Given this list of marker genes DLG1, CHAT, SNAP25, KCNJ8, TUBA1B, HCN3 (hyperpolarization activated cyclic nucleotide gated potassium channel 3), LIN7B, IL1RAP, LIN7A, HOMER2, KCNA2, PRKCG, PRKAR1B, RASGRF2, GRIP2, HCN2, GRIK3, KCNK16, GABRR1, SLC1A1, GABRR3, KCNV2, SYN1, NRGN, SHANK1, KCNH6, KCND3, GRIN2C, KCNG1, KCNK18, LRRC7, GABRA4, CACNG2, SLC6A4, ADCY4, PRKAR2B, GNG3, DLG2, RASGRF1, SLC6A3, TUBA1C, GRIK2, TUBAL3, SLC5A7, GABRR2, EPB41L5, SLC18A2, HRAS, KCNAB2, GNAL, AP2S1, KCNA7, VAMP2, PANX2, APBA2, EPB41, PRKAG3, KCNN2, ADCY5, SHANK2, GABBR1, SLITRK6, KCNN3, EPB41L1, TUBB6, SLC1A6, GABRB1, ABAT, PRKAG2, HOMER3, TUBB4A, GNAI3, KCNC1 (NCBI Gene Id 3746), NLGN2, DLG3, IL1RAPL2, GNG7, KCNAB1, PPFIBP1, KCNS1, PDPK1, LRFN3, PTPRF, CHRNA7, KCNH2, KCNS2, PPFIA3, NRG1, COMT, KCNK10, GRIN2A, SLC6A12, GNG12, KCNA1, KCNMB4, CHRNB3, GNG4, KCNK6, KCNA4, ACHE, SLITRK5, SLITRK4, KCNJ11, PPM1E, PRKAR1A, CREB1, GNG10, RPS6KA6 (NCBI Gene Id 27330), CHRNE, KCNJ9, LRRTM1, CHRNA2, KCNK7, GNB5, GNB2, RPS6KA1, CAMK2A, PRKACG, KCNC4, PLCB2, SLC17A7, STXBP1, AP2A2, GRM1, CACNA1E, STX1A, HTR3B, KCNH3, KCNQ2, PRKAR2A, GABRA1, GNG5, PLCB3, KCNMA1, MAOA, SLC6A11, TUBB3, CACNG4, CAMK4, EPB41L3, BCHE, PPFIA4, ADCY7, KCNMB3, ADCY1, KCNC2, DLGAP2, CAMK2G, KCNK9, PICK1, GLRB, GABRA3, KCNJ10, SLC38A2, ADCY3, GRIN3A, GRIA3, GAD1, DLGAP1, NEFL, CAMKK1, CAMK2B, SLITRK1, HOMER1, PDLIM5, CHRND, GABRQ, SLC38A1, SHARPIN, PRKACA, KCNA5, HTR3D, ALDH5A1, DLG4, ADCY2, DBNL, NSF, ADCY6, NLGN4X, KPNA2, SLC6A13, TUBA3E, KCNN1, NLGN3, GRIA1, CACNA1A, KCNK13, LRFN4, CHRNG, KCNH5, CASK (NCBI Gene Id 8573), GNGT2, SLC22A1, NCALD, KCNMB2, GABRG3, ARHGEF7, KCNH4, KCNF1, IL1RAPL1, TUBB8, DLGAP4, PPFIA1, LRRTM4, CACNA2D1, TUBA8, SLC22A2, CHRNA6, GABBR2, GIT1, GLRA3, SHANK3 (SH3 and multiple ankyrin repeat domains 3), KCND1, CHRNB4, UNC13B, GRIK4, CPLX1, ADCY8, KCNJ1, HTR3C, KCNB1, GABRB3, KCNQ3, ACTN2, PRKACB, PRKAB1, CHRNB2, LRFN1 (NCBI Gene Id 57622), SLITRK3, GRIK1, LRRTM2, PRKAG1, LIN7C, GNG8, KCNS3, HTR3A, PRKAA2, KCNK2, LRRTM3, KCNJ16, CHRNA5, GRM5, CAMK2D, GAD2, CACNB4, GABRA2, FLOT1, TUBB8B, TUBB4B, TUBA4B, PPM1F, GNG2, GABRB2, TSPAN7, NAAA, KCNJ6, AKAP5, GNB3, KCNG3, SRC, MAPK1, NLGN1, MAPK3, GNG13, ALDH2, SLC1A3, GLRA1, PRKAA1, GABRG2, TSPOAP1, ARHGEF9, DNAJC5, KCNH8 (NCBI Gene Id 131096), SYT10, KCNA6, TUBB1, GNB1, KCNK1, SLC6A1, GJC1, KCNA10, APBA3, KRAS, PTPRD, KCNJ2, BEGAIN, KCNJ12, KCNQ4, PRKAB2, KCNQ1, TUBA3C, KCNK17, KCNN4, SYN3 (synapsin III), SYT7, MYO6, PRKX, CACNB2, GNB4, ERBB4, GLS, RAC1, NPTN, SYT2, HCN4, NRAS, NRXN1, TUBB2B, PPFIA2, KCNJ15, TUBA4A, RPS6KA3, RPS6KA2, RAB3A, SYT1, NLGN4Y, GNAT3, KCNJ3, GNAI1, KCNK4, GRIA2, AP2A1 (NCBI Gene Id 92649), LRFN2, PLCB1, CACNG8, GLS2, GJA10, TUBB2A, NBEA, CHRNA1, TUBA3D (NCBI Gene Id 150778), GNGT1 (NCBI Gene Id 2792), ADCY9, CACNA2D3, CACNG3, CAMKK2, CACNA2D2 (NCBI Gene Id 9254), SYN2 (synapsin II), HTR3E, GNG11, PPFIBP2, NRXN2, FLOT2, HCN1, GJD2, PANX1, KCNG4, SLC32A1, RIMS1, KCNH1, KCNK3, GLRA2, KCNC3, KCNJ14, KIF17, CHRNA9, KCNB2, KCNH7, NRXN3, KCNJ4, GRIN1, GLUL, DLGAP3, APBA1, ARL6IP5, HSPA8, AP2B1, GABRA5, SLC1A7, CACNB1, GRIA4, PRKCB (NCBI Gene Id 5579), SYT9, SIPA1L1, CALM1, ABCC9, TUBA1A, CACNB3, KCNA3, MAPT, SLITRK2, RTN3, NTRK3, ABCC8, PTPRS, GRIN2D, PRKCA, MDM2, GNAI2, KCNAB3, GABRA6, LRRC4B, TOMT, CACNA1B, GRIP1, SLC18A3, KCNMB1, KCNG2 (potassium voltage-gated channel modifier subfamily G member 2), GRIK5, KCNV1, CHRNA3, EPB41L2, KCND2, CHRNA4, KCNQ5, CAMK1, GRIN2B, GRIN3B, KCNJ5 (NCBI Gene Id 3762), AP2M1, SLC1A2, SYT12, here is a description of the gene set: The human brain contains at least 100 billion neurons, each with the ability to influence many other cells. Clearly, highly sophisticated and efficient mechanisms are needed to enable communication among this astronomical number of elements. This communication occurs across synapses, the functional connection between neurons. Synapses can be divided into two general classes: electrical synapses and chemical synapses. Electrical synapses permit direct, passive flow of electrical current from one neuron to another. The current flows through gap junctions, specialized membrane channels that connect the two cells. Chemical synapses enable cell-to-cell communication using neurotransmitter release. Neurotransmitters are chemical agents released by presynaptic neurons that trigger a secondary current flow in postsynaptic neurons by activating specific receptor molecules. Neurotransmitter secretion is triggered by the influx of Ca2+ through voltage-gated channels, which gives rise to a transient increase in Ca2+ concentration within the presynaptic terminal. The rise in Ca2+ concentration causes synaptic vesicles (the presynaptic organelles that store neurotransmitters) to fuse with the presynaptic plasma membrane and release their contents into the space between the pre- and postsynaptic cells. Reactome Pathway: Neuronal System species: Homo sapiens